Given this list of marker genes ACADS, ACSM6, ECHS1, HADH, ACSM3, here is a description of the gene set: Reactome Pathway: Beta oxidation of butanoyl-CoA to acetyl-CoA species: Homo sapiens part of: mitochondrial fatty acid beta-oxidation of saturated fatty acids The seventh and final pass through the beta-oxidation spiral picks up where the last left off with the saturated fatty acid butanoyl-CoA and at the third step produces acetoacetyl-CoA, which can be used to generate 2 acetyl-CoA molecules or can be turned toward the synthesis of ketone bodies pathway. Four enzymatic steps are required starting with SCAD CoA dehydrogenase (Short Chain) activity, followed by the enoyl-CoA hydratase activity of crotonase, the 3-hydroxyacyl-CoA dehydrogenase activity of the short chain 3-hydroxyacyl-CoA dehydrogenase (SCHAD). The final enzymatic step, creating two acetyl-CoA molecules requires a specific ketoacyl-CoA thiolase, Acetoacetyl-CoA thiolase.